The following is a description of a gene set: Human Gene Set: HUANG_AML_LSC47 Relapsed or refractory pediatric acute myeloid leukemia (AML) is associated with poor outcomes and relapse risk prediction approaches have not changed significantly in decades. To build a robust transcriptional risk prediction model for pediatric AML, we perform RNA-sequencing on 1503 primary diagnostic samples. While a 17 gene leukemia stem cell signature (LSC17) is predictive in our aggregated pediatric study population, LSC17 is no longer predictive within established cytogenetic and molecular (cytomolecular) risk groups. Therefore, we identify distinct LSC signatures on the basis of AML cytomolecular subtypes (LSC47) that were more predictive than LSC17. Based on these findings, we build a robust relapse prediction model within a training cohort and then validate it within independent cohorts. Here, we show that LSC47 increases the predictive power of conventional risk stratification and that applying biomarkers in a manner that is informed by cytomolecular profiling outperforms a uniform biomarker approach. Genes up-regulated in AML leukemia stem cells (LSC) and predictive for outcome in AML from publication Huang BJ, Smith JL, Farrar JE, Wang YC, Umeda M, Ries RE, Leonti AR, Crowgey E, Furlan SN, Tarlock K, Armendariz M, Liu Y, Shaw TI, Wei L, Gerbing RB, Cooper TM, Gamis AS, Aplenc R, Kolb EA, Rubnitz J, Ma J, Klco JM, Ma X, Alonzo TA, Triche T Jr, Meshinchi S (PMID 36123353) studied in species Homo sapiens, and this is the list of marker genes: GPSM1 (G protein signaling modulator 1), SOCS2, BEX3, TNFRSF4, ANGPT1, ARHGAP22, HOXA6 (NCBI Gene Id 3203), INKA1, PRSS57, EPDR1, CPXM1, SPINK2, GATA2, SPNS2, MAMDC2, GCSAML, NYNRIN, AKR1C3, FAM30A, MMRN1, SKIDA1, CD34, BIVM, LAPTM4B, GUCY1A1, MYCN, SHANK3, VWF, COL24A1, ZBTB46, DIPK1B, DNMT3B, ADGRG1, ATP8B4, MOK, AIF1L, HOXA5, TFPI, EMP1, SMIM24, DPYSL3, CDK6, FLT3, MACROH2A2, HOXA9, KCNK17, FSCN1